The following is a description of a gene set: Non-medullary thyroid carcinoma studied in species Homo sapiens Human Gene Set: HP_NON_MEDULLARY_THYROID_CARCINOMA, and this is the list of marker genes: NRAS, HRAS, HABP2 (NCBI Gene Id 3026), SRGAP1, NKX2-1, MINPP1